The following is a description of a gene set: from publication Bhattacharyya S, Deb J, Patra AK, Thuy Pham DA, Chen W, Vaeth M, Berberich-Siebelt F, Klein-Hessling S, Lamperti ED, Reifenberg K, Jellusova J, Schweizer A, Nitschke L, Leich E, Rosenwald A, Brunner C, Engelmann S, Bommhardt U, Avots A, Müller MR, Kondo E, Serfling E (PMID 21464221) Genes down-regulated in B lymphocytes with NFATC1 knockout: control versus stimulated by anti-IgM for 8h. Human Gene Set: GSE21063_CTRL_VS_ANTI_IGM_STIM_BCELL_NFATC1_KO_8H_DN studied in species Homo sapiens Triggering of B cell receptors (BCR) induces a massive synthesis of NFATc1 in splenic B cells. By inactivating the Nfatc1 gene and re-expressing NFATc1 we show that NFATc1 levels are critical for the survival of splenic B cells upon BCR stimulation. NFATc1 ablation led to decreased BCR-induced Ca++ flux and proliferation of splenic B cells, increased apoptosis and suppressed germinal centre formation and immunoglobulin class switch by T cell-independent antigens. By controlling IL-10 synthesis in B cells, NFATc1 supported the proliferation and IL-2 synthesis of T cells in vitro and appeared to contribute to the mild clinical course of Experimental Autoimmune Encephalomyelitis in mice bearing NFATc1-/- B cells. These data indicate NFATc1 as a key factor controlling B cell function., and this is the list of marker genes: PIGN, FLOT1, PCCA, C17orf58, EDEM1, LINC00624, KIAA0586, MAD2L1 (mitotic arrest deficient 2 like 1), PLCXD1 (phosphatidylinositol specific phospholipase C X domain containing 1), NEDD4, CDCA2, MGMT, SRI, C1GALT1C1, STMN1, MRPS9, ARV1, ARHGAP18, MCCC1, VPS29, WDR70, FKBP15, TMA16, BLM, E2F7, BIVM, MAPKAPK3, C9orf40, CCR2, SPAG5, MNAT1, AEN, SRD5A1, TMEM79, COA6, BUB1B, PHF19, SLC35E4, POC5, PTGER2, TTLL12, ARHGAP19, NTHL1, GGCT, RNF167, ASF1B, TTK, CCDC138, ELP4, RNF187, CDK19, ZNF512, CDC25A, NSD2, RXYLT1, SNX5, TM7SF2, LSM4, FANCD2, VRK1, TYMS, SERPINB6, CDKN2C, CCDC25, CKS1B, RPS6KC1, ARHGEF6, ATF3, PHF14, DPAGT1, MCM5, HMGB3 (high mobility group box 3), CDPF1, ABCD2, NCAPH, MAP3K5 (mitogen-activated protein kinase kinase kinase 5), MDM1, IAH1, TOP2A, BCAS4, HJURP, ANP32E, CDRT4, B3GNTL1, NINJ2, FANCI, DGLUCY, NINJ2-AS1, GNPAT, LRR1, UCHL3, PRIM1, SEL1L3, KNTC1 (kinetochore associated 1), CENPU, DNPH1, CHEK2 (checkpoint kinase 2), TRIM46 (tripartite motif containing 46), LAGE3P1, CSTPP1, PAAF1, FIG4, CCDC14, TRERF1, ARHGEF9, ATP5MC1, PLAAT3, ANXA4, IARS1, RMDN1, PKM, GATAD1, HERC4, ANLN, RAD51, TFDP1, RFC3, STYXL1, VANGL1, DMC1, CBR3, TRAP1, ATIC, NUBPL, SKA1, EPRS1, NBAS, HMMR, RPL39L, TXN, CHID1, FUCA2, CHCHD3, TARS1, MTHFD2, MPV17, GMDS, GANC, PRKCE, AP3B1, ALS2, AKIP1, NUTF2, ZEB1-AS1, ITPR1, MCM10, DECR1, HDDC3, EXO1, RPL22L1, PYCARD, NCALD, GMPPA, ATP23 (NCBI Gene Id 91419), SIT1, NCAPG, CPPED1, AURKA, DUT, CSF1, SAC3D1, RIDA, CCNA2, MTHFD1L, TMEM107, ASPM, NRDC, PHLDA1, TMEM218, NAA35, HSD17B8, MAGOHB (NCBI Gene Id 55110), STN1, FUT8, PSRC1, SMIM20, DEPDC1B, RNASEH2A (NCBI Gene Id 10535), PKP4, PSME2, MCTS1, ERP44, SLC27A2, ORC3, BARD1, IDH1, MYL6B, COQ3, SMC2, SFXN4, BIRC5 (NCBI Gene Id 332), AP2B1, PIBF1, CCNB2, CENPO, HIRIP3, DONSON (DNA replication fork stabilization factor DONSON), KIF15